The following is a description of a gene set: Human Gene Set: HP_DARK_URINE An abnormal dark color of the urine. species: Homo sapiens Dark urine, and this is the list of marker genes: MT-CO1, PYGM, OBSCN, HMBS, MT-CO3, LPIN1, HGD, SAT1, IRAK1, CPOX, SPP1, IFT56, STAT4, ATP11C, MPV17, AKR1D1